The following is a description of a gene set: Any process that stops, prevents, or reduces the frequency, rate or extent of signaling via the stress-activated protein kinase signaling cascade. Human Gene Set: GOBP_NEGATIVE_REGULATION_OF_STRESS_ACTIVATED_PROTEIN_KINASE_SIGNALING_CASCADE species: Homo sapiens, and this is the list of marker genes: IGBP1, DUSP10, MAP3K20, QARS1, PPIA, FOXM1, FOXO1, GSTP1, PBK, MYC